Given this list of marker genes UBB, TAB3, IRAK2, UBC, UBA52, TAB2, TRAF6, TAB1, MAP3K7 (NCBI Gene Id 6885), RPS27A, here is a description of the gene set: IRAK2 mediated activation of TAK1 complex Human Gene Set: REACTOME_IRAK2_MEDIATED_ACTIVATION_OF_TAK1_COMPLEX studied in species Homo sapiens